Given this list of marker genes TNFRSF10A, MAP3K2, CHEK1, PTPN11, IL1B, PLEC, MAP2K4, KCNJ2, ABCB1, ANKRD1 (ankyrin repeat domain 1), TNFRSF10B (NCBI Gene Id 8795), TLR5, SOX9, DAG1, MAPK8, PECAM1, SLC38A2, GOT1, PTGER4 (NCBI Gene Id 5734), BMP6, AQP1, IL13, MYD88, TNFRSF8, HDAC3, GCLC (glutamate-cysteine ligase catalytic subunit), PIEZO1, PIEZO2, CDA, F11R, TLR7, COL1A1, TLR8, CASP1, MAP3K1, TNFRSF1A, FAS, NFKB1, TNFSF14, BCL10, CD40, MAP3K14, TMEM150C, ITGA2, ITGB3, SCX, ATP1A2, TGFB1, CASP8AP2, LTBR, CNN2, MAPK3, FADD, TLR4, KCNK4, BAK1, SLC2A1, CRADD, GAB1 (GRB2 associated binding protein 1), CASP8, BAG3, CASP2, IRF1, BAD, FGF2, MAG, CYBA, GADD45A, SLC9A1 (solute carrier family 9 member A1), PDE2A, TLR3, TEK, CASP5, HABP4, TMEM87A, BNIP3, WNT11, NPPA, here is a description of the gene set: Any process that results in a change in state or activity of a cell (in terms of movement, secretion, enzyme production, gene expression, etc.) as a result of an external stimulus. species: Homo sapiens Human Gene Set: GOBP_CELLULAR_RESPONSE_TO_EXTERNAL_STIMULUS